The following is a description of a gene set: Human Gene Set: GOBP_TRNA_5_LEADER_REMOVAL Generation of the mature 5'-end of the tRNA, usually via an endonucleolytic cleavage by RNase P. studied in species Homo sapiens, and this is the list of marker genes: POP4, RPP38, RPP14, RPP25L, RPP25, PRORP, POP1, RPP40, POP7, RPP30, POP5, RPP21, SSB